Given this list of marker genes USP20, SYN2, RAB17, AP2A2, TM7SF3, FBXL18, BIN2, LRFN4, TBC1D17, BEX4, FHOD1, SAC3D1, RALBP1, MTA1, FAM106A, ROBO4 (roundabout guidance receptor 4), CAMK2A, IPO9, B4GALT3, MYO1F, SNRNP200, SLC25A22, SMS, C2CD2L, MEA1, CDCA4, SPHK2, DNAJC1, MTRF1L, ST3GAL5, TTLL7, DTX3, PRKRIP1, GPR87, NANOG, LCN2, CEACAM3, OR3A1, MYCN, CLCN6, SCN3A, KCTD17, CLIC1, GPSM2, URB1, SNX6, ZBTB7A, VASH2, ERLIN2, KCTD5, NECAP2, KIF21B, AFM, AFF1, UBC, CTNNBIP1 (NCBI Gene Id 56998), KMT5A, LRFN3, NBN, CEP170, RGS19, TSNAX, ACAT2, ROBO3, PDLIM2, DHCR7, NUP205, RAPGEF1, PRDM14, PLAT, TLL1 (NCBI Gene Id 7092), SYT17, MSMO1, HMGCR, TCF7, TPPP, ETV5, B3GALT4, DCP2, TCF25, ZNF629, CRTC3, GAL3ST4, PAK2, MCM3AP, FADS1, KCNA4, PANK3, CCND3, SRSF6, P2RX1, SQLE, SC5D, CENPF, CNN2, MICB, PLA2G3, TPST2, PCGF3, TK2, METTL3, KLC1, PLA2G2F, PIAS3, COL9A3 (collagen type IX alpha 3 chain), ZNF180, HTT, ATF5, GSTA1, LMO2, ASCC2, B3GNT3 (UDP-GlcNAc:betaGal beta-1,3-N-acetylglucosaminyltransferase 3), FOXO3, SPECC1L, ELK4, NKIRAS2, KDM3B, RHBDF1, GSG1, NOC2L, CORO1C (NCBI Gene Id 23603), C3AR1, SNHG20, LBHD1, SLC9A1, SRF, GJC2, MYRIP, COLGALT2, MYLK3 (myosin light chain kinase 3), LLGL2, RRAS, FSTL3, CSK, BTNL3, TRAF2, CBX4, ADCY3, HOXB2, CYFIP2, PRC1, EIF2S3, MICAL3, CHRNA10, SPCS1, TERT, CAD, KIF18B, LAMC3, PIMREG, KCNB1, ZNF551, ACTMAP, NCOR2, ADORA3, NUP85, DCX, PTPN18, AHCTF1, JUP, MKNK2, SLC1A2, GAL3ST1, TBXA2R, CD33, AGFG2, SLC5A7, FBXO24, PRKCA, SLC35E1, NMU, PACSIN2, TMEM184B, ZFHX4 (zinc finger homeobox 4), CDC42BPB, EML3, F10, RGS14, SELPLG, PAXIP1, MYOD1, NDE1, EHMT2, IRF3, FADD (Fas associated via death domain), SCMH1, HNRNPK, GNB2, PLA2G15, TRAPPC2, RHOT1, JUND, ANKRD27, NCK2, NUP62, here is a description of the gene set: species: Homo sapiens Genes up-regulated in CD4 T cells: control versus Ro 41-5253. Human Gene Set: GSE20500_CTRL_VS_RARA_ANTAGONIST_TREATED_CD4_TCELL_UP This is to determine the T cell genes regulated by retinoic acid. from publication Kang SG, Park J, Cho JY, Ulrich B, Kim CH (PMID 20664575)